The following is a description of a gene set: Hypoplastic fifth toenail species: Homo sapiens Human Gene Set: HP_HYPOPLASTIC_FIFTH_TOENAIL Underdeveloped nails of the fifth toes., and this is the list of marker genes: SOX4 (NCBI Gene Id 6659), SOX11, KRT5, SMARCD1, DPF2, ARID1A, PPP2R5D, ARID1B, SMARCB1, SMARCE1, SET, HOXA13, SMARCA4, ARID2, SMARCC2, MSX1